Given this list of marker genes Neo1 (neogenin), Scube3, Bmp3 (NCBI Gene Id 319746), Bmp6, Bmp2, Bmp4, Pycard (PYD and CARD domain containing), Bmp7, Elapor2, Acvr1c, Src, Cdh5, Rspo2, Bmp5, here is a description of the gene set: Mouse Gene Set: GOMF_BMP_RECEPTOR_BINDING Binding to a BMP receptor. studied in species Mus musculus